The following is a description of a gene set: Catalysis of the transfer of sialic acid to an acceptor molecule, typically the terminal portions of the sialylated glycolipids (gangliosides) or to the N- or O-linked sugar chains of glycoproteins. Mouse Gene Set: GOMF_SIALYLTRANSFERASE_ACTIVITY species: Mus musculus, and this is the list of marker genes: St8sia6 (NCBI Gene Id 99126), St3gal1, St8sia3, St6galnac5, St8sia2 (NCBI Gene Id 20450), St3gal3, St8sia5, St3gal5, St3gal4, St6gal2, St3gal2, St6galnac2, St8sia4, St8sia1, St6galnac6, St6galnac1, St6galnac3, St6gal1, St6galnac4, St3gal6, 6430550D23Rik